Given this list of marker genes Trim27, Gmfb, Arpc1a, Hip1r, Scin, Lmod3, Carmil2, Arpc2, Carmil1, Actr3, Wmp, Pick1, Inf2, Rnh1, Spire1, Arpc1b, Coro1b, Lmod2, Jmy (NCBI Gene Id 57748), Arf1, Arpc5, Arpc5l, Arfip1, Nckap1, Evl, Fmn1, Lmod1, Fmn2, Dnai3, Gm28729, Gmfg, Wasl (NCBI Gene Id 73178), Diaph3, Iqgap2, Gsn, Arfip2, Cyfip1, Diaph1, Wasf1, Wasf3, Magel2, Ctnna2, Wasf2, Fchsd2, Carmil3 (capping protein regulator and myosin 1 linker 3), Arpin, Wipf3, Washc2, Washc5, Brk1, Washc1, Abi2, Arpc3, Vil1, Washc4, Coro1a, Actr2, Arpc4, Whamm, Washc3, Spire2, Ap1ar, here is a description of the gene set: species: Mus musculus Mouse Gene Set: GOBP_ACTIN_NUCLEATION The initial step in the formation of an actin filament, in which actin monomers combine to form a new filament. Nucleation is slow relative to the subsequent addition of more monomers to extend the filament.